Given this list of marker genes KCNB1, PUM1, CHD8, VAMP2, CDKL5, GRIA2, NACC1, NTNG1, H4C5, CELF2, ZBTB18, GABBR2, GRIN1, GRIN2A, CACNA1B, DYRK1A, LARP7, IQSEC2, DHX30, NEXMIF, MGAT2, HDAC4, SATB1, CNTNAP2, SMC1A, CASK, GNAI1, MECP2, AP1S2, LMNB1, here is a description of the gene set: Hand stereotypies within the medial plane of the body. Midline hand movements species: Homo sapiens Human Gene Set: HP_MIDLINE_HAND_MOVEMENTS